The following is a description of a gene set: studied in species Homo sapiens Genes repressed in SKBR3 cells (breast cancer) by 25-hydroxyvitamin D3. from publication Stambolsky P, Tabach Y, Fontemaggi G, Weisz L, Maor-Aloni R, Siegfried Z, Shiff I, Kogan I, Shay M, Kalo E, Blandino G, Simon I, Oren M, Rotter V (PMID 20227041) Human Gene Set: STAMBOLSKY_RESPONSE_TO_VITAMIN_D3_DN The p53 gene is mutated in many human tumors. Cells of such tumors often contain abundant mutant p53 (mutp53) protein, which may contribute actively to tumor progression via a gain-of-function mechanism. We applied ChIP-on-chip analysis and identified the vitamin D receptor (VDR) response element as overrepresented in promoter sequences bound by mutp53. We report that mutp53 can interact functionally and physically with VDR. Mutp53 is recruited to VDR-regulated genes and modulates their expression, augmenting the transactivation of some genes and relieving the repression of others. Furthermore, mutp53 increases the nuclear accumulation of VDR. Importantly, mutp53 converts vitamin D into an antiapoptotic agent. Thus, p53 status can determine the biological impact of vitamin D on tumor cells., and this is the list of marker genes: IPP, CDS2, NAALADL2, LINC02481, SLC38A9, PIGR, HMGN4, SEMA3F, ATP6V0A4, DAPK1, EFS, MEAF6, MAML2, KAT2B, TXNIP, ZNF232, NRF1, RPL10L, CKLF, CABYR, C6orf52, NUP54, HBA2, COL5A1, FBXO32